The following is a description of a gene set: Genes down-regulated in comparison of immature NK cells versus mature NK cells. Previous reports have defined three subsets of mouse NK cells on the basis of the expression of CD27 and CD11b. The developmental relationship between these subsets was unclear. To address this issue, we evaluated the overall proximity between mouse NK cell subsets defined by CD27 and CD11b expression using pangenomic gene expression profiling. The results suggest that CD27+CD11b-, CD27+CD11b+ and CD27-CD11b+ correspond to three different intermediates stages of NK cell development. from publication Chiossone L, Chaix J, Fuseri N, Roth C, Vivier E, Walzer T (PMID 19234143) species: Homo sapiens Human Gene Set: GSE13229_IMM_VS_MATURE_NKCELL_DN, and this is the list of marker genes: NAA38, CHD1L, ARHGEF2, LRRC71, TRIM3, DCAF5, RPL36, TYRP1, AKT2, TGFB1, MEX3D, FCGR2A, RASL12, COX14, RAP1GAP2, USP40, PIP5K1C (NCBI Gene Id 23396), ISG15, CYB5R1, ITGAX, PTK2B, PLEKHG3, SLC22A9, CLIC5, EXOSC6, MPV17, BLOC1S2, SCAMP3, AMDHD2, PEX10, INPP5D, SELENON, GPBP1L1, KCNG4, KCNK5, NIBAN2, TSPAN5, KLF10, UTP23, TIMM13, DUSP8 (dual specificity phosphatase 8), TTC38, SLC9A9, TMEM163, HCRTR1, PIK3R2, CLBA1, B3GNT7, RBMS2, PTPN22, FAT4, ORAI2, FCER1G, SNX15 (NCBI Gene Id 29907), RING1, B3GNT5, KLHL42, RANBP17, FUCA2, KCNQ5, ME1, CCDC17, AIRN, ZFP14, TCF25, HARBI1, BAIAP3, DENND10, GZMB, AP3B2, VAC14, KRT86, WIPI2, TBC1D8, TARBP2, CX3CR1, TMEM106C (NCBI Gene Id 79022), CDH22, AP1G2, RAP2A, AGPAT3 (1-acylglycerol-3-phosphate O-acyltransferase 3), L1CAM, MCEE, MDM1, PGPEP1, PLCB1, USP48, RPS6KA4, GLE1, CMKLR1, NUCB2, PIK3C3, NAIF1 (nuclear apoptosis inducing factor 1), TYROBP, CEP152, MAPK3, CEP250, ARF1, F2RL2, ZBTB9, WDR45, TCN2, MLYCD, NSMCE4A, ANXA2, AGPAT2, ATF6B, KCNIP3, DCLRE1B, TMEM35B, TRAPPC2, ARHGEF18, UNC5D (unc-5 netrin receptor D), SYT11, CARD11, RRAS, SLC25A2 (solute carrier family 25 member 2), BAG3, AMZ1, FANCG, RHBDD1, ZNF524, CMTR1, UQCR10, GPS2, DNAJC18, CD300LB, MAGEF1 (NCBI Gene Id 64110), AARS1, PRF1, INPP5K, S100A1, ZEB2, CLCN4, PRKAA2, NQO2, TMEM200C, ST7L, GET4, MPND, SLC66A3, FBXO46, RGS17, ENPP5, GPR158, SRP68, SPN, IFFO1, NHSL2, TM9SF4, PSD, SCNM1, PACS1, CAMK2N1 (NCBI Gene Id 55450), CHMP3, CD2 (CD2 molecule), IL11RA, ATRNL1, CYTH2, SLC16A2, CNPPD1, NT5C3A, MED6, MAPK14, PADI4, RPA2, DECR2, CST7, KHDC1L, ENTPD1, MKLN1, MAGI3, CYP11B1, SAP30L, COL8A2, LPIN1, BRINP3, LINC00511, CERK, TRIML1, VIM, DNAAF5, NEDD1, STRIP1, CIZ1, INTS12, PALD1, ZBTB48, HNRNPA0, EIF2AK1, KRT222, EPHX1, EPDR1, CCDC88B, CARD19, SH3BGRL3, PPM1D, CMA1, CAPNS1, NR3C2